The following is a description of a gene set: Human Gene Set: SENESE_HDAC1_TARGETS_DN Genes down-regulated in U2OS cells (osteosarcoma) upon knockdown of HDAC1 by RNAi. studied in species Homo sapiens from publication Senese S, Zaragoza K, Minardi S, Muradore I, Ronzoni S, Passafaro A, Bernard L, Draetta GF, Alcalay M, Seiser C, Chiocca S (PMID 17470557) Posttranslational modifications of core histones are central to the regulation of gene expression. Histone deacetylases (HDACs) repress transcription by deacetylating histones, and class I HDACs have a crucial role in mouse, Xenopus laevis, zebra fish, and Caenorhabditis elegans development. The role of individual class I HDACs in tumor cell proliferation was investigated using RNA interference-mediated protein knockdown. We show here that in the absence of HDAC1 cells can arrest either at the G(1) phase of the cell cycle or at the G(2)/M transition, resulting in the loss of mitotic cells, cell growth inhibition, and an increase in the percentage of apoptotic cells. On the contrary, HDAC2 knockdown showed no effect on cell proliferation unless we concurrently knocked down HDAC1. Using gene expression profiling analysis, we found that inactivation of HDAC1 affected the transcription of specific target genes involved in proliferation and apoptosis. Furthermore, HDAC2 downregulation did not cause significant changes compared to control cells, while inactivation of HDAC1, HDAC1 plus HDAC2, or HDAC3 resulted in more distinct clusters. Loss of these HDACs might impair cell cycle progression by affecting not only the transcription of specific target genes but also other biological processes. Our data support the idea that a drug targeting specific HDACs could be highly beneficial in the treatment of cancer., and this is the list of marker genes: SOX2, PCDHB10, SYNC, IMPA2, GALNT16, DPY19L4, CSDC2, GLIS2, MYBL1, TCEA2 (transcription elongation factor A2), CRISPLD1, CAVIN1, HSPB2, SDC3, MRC2, APLP1, IFT74, LRRFIP1, BAZ2B, TP53TG1, TTYH1, CRIM1-DT (NCBI Gene Id 100509421), GOLM1, NUDT6, C1QTNF12, GSTM4, BCAR1, TPM4, GPC4, ASS1, NHSL3, CCSAP, ZNF827, TRO, EFNB3, NREP, DYNLL2 (dynein light chain LC8-type 2), EBF1, BAIAP2, EPS8L2, FSTL1, SLC15A4, RNFT1, ZDHHC12-DT, MALAT1, PBX1, LSP1P5, LINC02984, SESN3, MYL9, ZNF395, CXXC5 (NCBI Gene Id 51523), FKBP7, FOXS1, YPEL2, PCDHB5, MEIS1, BTBD2, MPP7, FADS1, RBPMS, L1CAM (L1 cell adhesion molecule), RASSF4, CRMP1, SLX4IP, SMIM14, ARID5B, NOX4, PTPRN, ARHGEF40, MDP1, LSS, EFCAB2, TMEM135, CMC4, OBSL1, SSH3, DKK3, ELFN2, CCNG2, NXPH2, ITGA7, RNF187, TCAF1, UTRN, BNIP3L, MAF (NCBI Gene Id 4094), ZBED5-AS1, DOK1, GPATCH2, EPHB2, PARK7, HR, AP1G2, FXYD6, STMN3, SNORD60, ORAI2, HDLBP, TUBA1A, MTSS2, CNPY4, MIR497HG, ROCK2, NOTCH3, COL5A1, FAM114A1, TNS1, LAMTOR5-AS1 (NCBI Gene Id 101410535), SDC1, CBX5, FBLN1, LSP1, NAP1L3, CD46, PIN1, LACTB, SNHG33, CNN3-DT, TUBB2B, FDFT1, PRKCA, NARF, CYTL1, FAM200C, ENAH, CDC42EP3, FLYWCH2, EIPR1, DAB2, COL1A1, TMEM132D-AS1, GXYLT2, THRB (NCBI Gene Id 7068), SCN2B, INKA2, PDE1C, DHRS2, SYT17, COPZ1, PRAG1, KCNA1, KRT7, HCFC1R1, DNAJC1, FOS, COL11A1, SET, TRIM2, MYH10, CYTH2, TGFB2, ALOX5 (NCBI Gene Id 240), MAGED4B, SLC38A10, LAMB2, MYRF, PYGL, C11orf96, EPB41L5, FOLR1, F2R, KLF7, PGRMC2, HMGCR, MAGED1, SYTL5, ICAM3, CCSER2, RAC1, CSRP2 (cysteine and glycine rich protein 2), ZNF404, GPR137C, SMARCA1, NFE4, TGFBI, P3H2, GLI2, GSTM1, TIA1, NLRP1, ERGIC1, TCEAL2, NFIA, PALM3, FGFR1, JAKMIP2, IDH2, HAPLN1, BCAM, PHLDB2, SEPTIN6, RHOBTB3, ARHGAP35, MYLK, ZNF260, KLHL22, COL12A1, TLCD4, HDAC1, LAMA5 (laminin subunit alpha 5), GET1, CIRBP, FOXO6, CDC42, IGFBP5, CADM3, IFI6, EDIL3, ZNF608, RUNX2, LOXL4, ZNF503, LDLRAD4, CHMP3, BNC2, FAM171A1, ABCC3, TOX3, CPE, SAMD1, PNMA2, LRRN1, TIAM2, AHNAK, PKD2, GSN, DNAJB2, TPGS2, ADGRB2 (adhesion G protein-coupled receptor B2), SIAE, BMP4, CFAP95, COL16A1, IQCA1, VXN, S100A10, IRS1, ID4, KLRK1-AS1, ALDH6A1, LINC02615, TK2, CNN1, CYS1, HSD17B10, TNFRSF13C, AASS, TRIM6, MATN3, RASA4, NXN, NRBP1, LYPD1, SOX12, PLEKHH1, FAM226B (family with sequence similarity 226 member B), COL3A1, MIAT, VAMP7, NMT2, TMEM120B, EFEMP2, ALDH5A1, CDC25C (cell division cycle 25C), TCF4, MIR1915HG